Given this list of marker genes CSF1, GDF15, SPARC, TAGLN3, CRYAB, PODXL, DHRS3 (NCBI Gene Id 9249), VSIR, IGF1, ECM1 (NCBI Gene Id 1893), ID3, CAMK2N1, CCL2, ANGPTL4, ITPR3, LGALS9, GPRC5A, ATP8B5P, LRRC61, UPP1, SPRY4, COL3A1, TMEM130, LINC00867, CRYAA, TMEM44, IFITM2, IFI27, BCAM, EBF4, CA10, IL32, BST2, CD53 (CD53 molecule), PIPOX (NCBI Gene Id 51268), IFITM1, S100A13, NOS1, LPCAT2 (NCBI Gene Id 54947), TAGLN, LGALS3BP, MKX, SLC15A2, PARVA, AHNAK, SLC25A3P1, NUPR1, EGFLAM, MMP2, LINC02532, here is a description of the gene set: Genes up-regulated in SW-13 cells (kidney cancer) by transient expression of SMARCA4 at 24 h off a plasmid vector. The mammalian BAF complex regulates gene expression by modifying chromatin structure. In this report, we identify genes activated and genes repressed by the BAF complex in SW-13 cells. We find that prior binding of NFI/CTF to the NFI/CTF binding site in CSF1 promoter is required for the recruitment of the BAF complex and the BAF-dependent activation of the promoter. Furthermore, the activation of the CSF1 promoter requires Z-DNA-forming sequences that are converted to Z-DNA structure upon activation by the BAF complex. The BAF complex facilitates Z-DNA formation in a nucleosomal template in vitro. We propose a model in which the BAF complex promotes Z-DNA formation which, in turn, stabilizes the open chromatin structure at the CSF1 promoter. Human Gene Set: LIU_SMARCA4_TARGETS from publication Liu R, Liu H, Chen X, Kirby M, Brown PO, Zhao K (PMID 11509180) studied in species Homo sapiens